Given this list of marker genes HBB, SEMA4D, ZNF148, FRA10AC1 (NCBI Gene Id 57208), DNAAF5, AFF4, VEGFC, ABL1, FANCF, FANCD2, HOXA1, SH3PXD2B, FOXC2, EPHB4, MMP14, INTU, DOCK6, KYNU, DNAJC30, C1R, BMPR1A (NCBI Gene Id 8035), PRDM13, UBAC2, SC5D (NCBI Gene Id 6309), BRAF, CDC42BPB (CDC42 binding protein kinase beta), ERCC6, B3GLCT, WLS, KCNJ8, MED13L, SUCLG1, AGPAT2, TPM2, PPARG, DNMT3A, UBE4B, PKD1L1, SALL4, LPL, EIF4A2, TBL2, CIROP, RNASEH2B, ADK, NOD2, POLR1D, MAPKAPK5 (MAPK activated protein kinase 5), RPL8, HCCS, NEK10, SMPD1, AKT1, BSCL2, SALL1 (NCBI Gene Id 6299), GLI2, PRPF3, SKI, RAD51C, IL10, PPP1R17, MMP2, LTBP1, UBE2T, SMARCE1, LDLR, HRAS, THSD1, SMAD4, NAA20, RPS7, SLC34A2, PIK3CA, NAA60, RAC1, CWC27, DACT1, MKKS, MAX, LMBRD1, FANCL, NOTCH3, CASZ1, COG4, ALG8, NAA10, ABCC6, SLC29A3, DAW1, RRAS, FOXP2, YY1, APOB, ADAMTS17, EGFR, ASCC1, CRB2, FGFR2, RAB34, EXT2, PDCD10, C12orf57, CRELD1, IL12A-AS1, TBX1, RNU4-2, GALNT3, GABRD (NCBI Gene Id 2563), ARID2, HNRNPK, RRAS2 (RAS related 2), PRKACB, ADAMTS19, MPL, CYP1B1, GNA11 (G protein subunit alpha 11), MCTP2, DNAAF4, CR2, XYLT1, HEXA, TAOK1, MED11, CCDC47, RIT1, DHCR7, IL12RB1, APOE, CYP27A1, CRTAP, RBM8A, KCNQ2, ARFGEF2, DPYSL5, KCNN3, SCN2A, SMARCD1, SRCAP, ENG, ECE1, MYPN, CXCR2, P4HA2, SON, IL23R, FUT8, CLXN, ERMARD, RPL35A, SMG8, MYOCD, ADAMTS10, ATP6V1B2, HSPG2, ODAD4, TBX20, TEK, AXIN1 (NCBI Gene Id 8312), BAZ1B, MT-ND4L, SYK, DCDC2, POLR1A, PRDM6, METTL27, TTC12, TMEM270 (NCBI Gene Id 135886), PORCN (NCBI Gene Id 65017), SIX3, MASP1 (NCBI Gene Id 5648), CEP295, EIF4H, UFD1, RASA1, NF1, PLAGL1, FIBP, SF3B2, NODAL, MMP23B, CFC1, PPP2R1A, ZIC3, APP, FAT4, COL1A1, GLB1, F12, UFC1, MYCN, APOA2, TBX5, FADD, CHUK, COMT, RAI1, DOCK8, CCNQ, GLYCTK, DNAI1, NFIX, CSF2RB, SOX4, SOS1, EIF2AK3, LIPA, DIS3L2, SNRPN, DNAJB13, EPHX2, TCF4, LAMB2, PTDSS1, NFIA, RPL11 (ribosomal protein L11), MT-CYB, PRKCD, IL12B, SLC37A4, ALX3 (ALX homeobox 3), CFAP300, PGM1, KCNAB2 (potassium voltage-gated channel subfamily A regulatory beta subunit 2), BPTF, UQCRFS1, DYNC2LI1, NADSYN1, ERCC4, ZIC2, NFKBIL1, RPL18, CD96, TBX4, DNAAF1, TGFBR3, MSX2, FGFR1, LZTR1, SPECC1L, PIK3CD, TMEM94, CFAP298, SLC20A2, DARS1, PSMD12, PACS1, POU3F4, NPC1, KRIT1, KDM5A, PDGFRB (platelet derived growth factor receptor beta), DHCR24, GLI3 (NCBI Gene Id 2737), COQ4, SIK3, MS4A1, RNF213, FOXC1, ERF, LIPC, MAD2L2, DNAAF2, RPS20, TRAF7, ODAD3, UBR7, TNFSF12, MRAS, FOCAD, CTSA, FANCC, RPL5, PIK3R2, NIPBL, PEX1, LEMD2, SEC63, KLRC4, NME8, GEMIN4 (gem nuclear organelle associated protein 4), SLC12A3, PALB2, SMARCA2, FANCA, ZEB2, CLCNKB, GP1BB, SH2D1A, CHD4, HTRA2, COL5A1, NDP, TREX1, GLMN, ROBO1, LRP6, CITED2, NEK9, ARVCF, LFNG, LMX1B, ADAT3, KMT2A, DISP1, IGBP1, CASP10, MLX, PLOD3, SMG9, MAP3K7, MEFV, SERPIND1, VPS37D, NDUFB11, LDLRAP1, LCAT, JAG1, PKD2, GATA4, EED, SCAF4, ZNF687, SUFU (NCBI Gene Id 51684), HLA-DRB1 (major histocompatibility complex, class II, DR beta 1), CPLANE1, LRRC56, HIBCH, TRRAP, SMARCA4, SOX10, WBP4, MT-ND5, BRCA2, LRP5, RPS29, TRIP11, RIN2, MT-CO3 (mitochondrially encoded cytochrome c oxidase III), RFC2, SOS2, BUB1, FANCB (NCBI Gene Id 2187), G6PC3, NEDD4L, ZMYM3, CCDC22, TONSL, DDX6, RSPH1, DNAI2, KAT6A, IFNGR1, HACD1, PPP1R15B, IDS, PCGF2, PKP2 (NCBI Gene Id 93271), NEK8, GPIHBP1, RASA2, CXCR4, IFT56 (intraflagellar transport 56), MT-ND6, WRN, RPGRIP1, SAMHD1, RSPH9, SMC5, FOXF1, AGGF1, TULP1, PRKG1, CBL, NXN, WDR35, CFAP53, PIK3CG, LTBP4, CCNO, POLA1, BUB3, SLC2A10, KDM6A, RPS24, PDPN, TBK1, FMR1, HYMAI, PIGL, ASAH1, STX5, TAF4, GAS1, DRC1, THPO, SPRED2, LYN, CDH2, SCN9A, AGO2, KDR, TWIST1, CSGALNACT1, HDAC4, QRICH1, CFAP74, COX7B, WASHC5, HEY2, GPR35, TMCO1, RPL15, ALDH1A2, GDF2, NCAPG2, SIX6, FBXO11, EMILIN1, ARID1A, GUCY1A1, NPPA, NFKB1, EBF3, TNNT2, SMARCB1, NOTCH1, SHH, THBS2, HYDIN, ODAD1, RPL26, SKIC2 (SKI2 subunit of superkiller complex), HLA-B, ATP2B1, RPS19, DDX59, FANCI, PSAP, MNX1, B3GAT3, IDH1, GBA1, IFT43, GJA8, PGM3, ITPR1, BRD4, OTUD5, JMJD1C, RPL31 (ribosomal protein L31), CREBBP, HCK, GUSB (glucuronidase beta), BANF1, DMPK, MT-ATP6, NLRP3, TRAIP, ATP6V1A, TGFBR2, ANK1, FANCE, COL18A1, NKX2-5, NIPA2, FAS, PDE11A, CELA2A, SPTBN1, PCSK9, CTCF, TMEM260, WNT4, STK36, APOA5, DGCR8, STAT3, GAA, MYRF, WAS, DNAL1, SPEF2, POLR1C, OFD1, GTF2IRD2, RPGR, FBXL4, GM2A, ZFPM2, MEIS2, SUPT16H, SLC39A13, WIPF1, CACNA1C, GAS2L2, MEGF8, LIFR, PKD1, SMAD2, EOGT (EGF domain specific O-linked N-acetylglucosamine transferase), HLA-DPA1 (major histocompatibility complex, class II, DP alpha 1), FASLG, VPS33A, FUCA1, CADM3, EZH2, DYRK1A, CAVIN1, RNASEH2A, RPS10, TNFRSF13B, CEP19, RTL1, GNPAT, MED25, JAK2, RSPRY1, GPC3, ANKS6, HEATR3, BICC1, CTLA4, BRCA1, AGXT, LIMK1, KCNT1, DDX11, BCOR, ODAD2, PTPN22, PRKCSH, CDON, PAH, GATA5, PCNT, SLC22A4, SFTPB, RPS28, EHMT1, AEBP1, PTCH1, RBP4, ACTB, KAT8, ABCD4, ICOS, IL6, ZBTB7A, CCR1, DNAH11, RFWD3, FGFR3, NKAP, COL3A1, SHANK3, DYRK1B, ARX, CDK8, PROS1, STAT1, LOX, DNAJB11, HIRA, PHGDH (phosphoglycerate dehydrogenase), RREB1, SMOC1, MGAT2, TLL1, PLOD1, TALDO1, PDGFB, GPC6 (NCBI Gene Id 10082), YME1L1, BUB1B, MT-ND4, RAD51, SMARCAL1, OTULIN, BRCC3, TRIP4, MEF2A, SSR4, DPM1, UMPS, FARSB, PLXND1, IGFBP7, LARS2, TELO2, SLX4, PNP, UNC45B, TNXB, ACTA2 (actin alpha 2, smooth muscle), CHRM3, TNFSF11, HYOU1, MED12, TBC1D24, CFI, ALG5, RET, RNU4ATAC, GGCX, CYP7A1, MCIDAS, DNASE1L3, AASS, BCR, DGCR6, POLR1B, DVL3, IL12A, PAK2, PPFIBP1, OCLN, GALC, TPM3, THSD4, UBE2A, ALX4, RERE, BRF1, TBCK, USP18, ABCC9, NPR3, MAF, TAB2, PIGO, PSTPIP1, BGN, PTPN6, RPS27, DTNA, NEK1, MID1, PTEN, TRPV6, FBN2, NFKB2, PTPN11, NPC2, CFAP221, LTBP2, TBX2, KIF5A, CCM2, NPHP3, FOS, CDC42, HLA-DPB1, DNAH5, PROC, COA6, APC2, MYH3, ARL6IP6, KDM3B, TSC1, IFNG, TSC2, BRIP1, PRKCZ, SEC24C, TP63, ADAMTSL1, GJA1, FBLN5, C1QB, WAC, RPL35, APOA1, RPS26, CEP120, NIPA1, B3GALT6, FLT4, SKIC3, ARID1B, DNAH9, SOX2, NDE1, VPS35L, ZNF699, CSF2RA, FLNA, PRKAR1A, CCDC40, LSM11, TRIO, RPL9, IFIH1, MAP1B, ATP7A, ZMYM2, ALDH18A1, HTRA1, STXBP1, PPP1CB, XYLT2, RAF1, GHR, DDX3X, KNSTRN, NAE1, ENPP1, RBPJ, MKS1, NSMCE2, GMPPB, KMT2B, COL5A2, DPH5, FIG4, ALG3, CD81, STX1A, BMPR2, CLCN7, CHD7, TGFB3 (NCBI Gene Id 7043), LUZP1, ACP5, BICRA, NSD1, SMAD3, BCL11B, CAV1, ALMS1, XRCC2, KANSL1, WDR19, EFEMP2, PLCB1, PIGN, IRF2BP2, DPF2, PIGT, ADAMTS3, RPS17, TUBG1, RSPH3, KCNE5, FBN1, PLCH1, EP300, DLK1, TFAP2B, TSFM, ANAPC7, EIF2AK4, ELN, PIGA, MYOC (NCBI Gene Id 4653), CHST3, PLD1 (NCBI Gene Id 5337), SRY, SEMA3E, TMEM127, PYCR1, ZFX, AMER1, ESS2, C2CD3, FKBP6, RPS15A, ACVR2B, YY1AP1, FGF8, ARHGAP31, CLIP2, STAT4, PEX12, SELENOI, RAP1B, DLL3, CNTN1, SMC3 (NCBI Gene Id 9126), GANAB, ROBO4 (roundabout guidance receptor 4), ADA2, NEU1 (neuraminidase 1), RAD21, ZSWIM6, GJA5, MMP21, VHL, MT-ND1, NT5E, PUF60, TNFRSF13C, FTO, HEXB, CD19, ZNF462, MYH7, DNAAF6, DOHH, GDF1, ANGPT2, NOTCH2, IPO8, ESR1, SCN1A, CTU2, ABCA1, ALG12, HES7, MFAP5, RSPH4A, KAT6B, MAT2A, STAG2, SPEN, THOC6, MT-ND2, RNU7-1, TGFB2, PAM16, TSR2, FLNB, GJC2, FKBP14, FOXH1, RPL27, FOXE3 (forkhead box E3), UBR1, ESAM, SMC1A, ACSL4, TGIF1, PRIM1, SCN11A, ALG9, SNX14, POGZ, MESP2, ESCO2, TGDS, PEX19, COL1A2, PIEZO1, CD244, STRA6, GPC4 (NCBI Gene Id 2239), TNFRSF1A, FKTN, CCBE1, HPGD, ZMIZ1, NME5, RBM10, IFT140, ATP6V0A2, CIITA, WDR37, ALB, ERAP1, PRDM16, FGF10, WDPCP, SMAD6, TLR4, ADH5, MVK, SDHD, KCNH1, MRPS16, ANO1, FZD4, FANCG, ERCC5, SAMD9, SNX10, GATA6, FOXJ1, ABCG5, ERCC8, RPL10, ROR2, TCIRG1, GTF2IRD1, TMEM67, POLR3F, SLC25A24, ACVRL1, TMTC3, PNPLA2, BMP2, MYLK, CALM3, DLL1, DNAH1, PRTN3, PIK3R1, CRIPTO, MYD88, GNAQ, FANCM, AMMECR1, TRIP13, WT1, PTH1R, NRAS, EFEMP1, CEP57, ATN1, BUD23 (NCBI Gene Id 84118), SLC35A2, XIAP, IGF2, COG6, NCF1, RAB23, EXT1, DLL4, GTF2I, ASXL2, ERCC3, ABCG8, OSGEP, ANTXR1, CCDC39 (coiled-coil domain 39 molecular ruler complex subunit), ADAR, UBE3B, DEPDC5 (DEP domain containing 5, GATOR1 subcomplex subunit), USP9X, MGP, C1S (complement C1s), MAPK1, ANGPTL6, COL4A1, SCN10A, HGD, GATA1, CRKL, ZMPSTE24, RNASEH2C, LMNA, C4A, SPAG1, CARS1, ARF1, DNAAF3, STIL, PLCB3, MST1, BAP1, MYH11, SOX11, NKX2-6, RIPPLY2, TCOF1, BEST1, UBA1, CHRNG, PBX1, SLC25A22, VAC14, TKT, NONO, CUX1, SNRPB, ERCC2, POLR3A, CAT, SLC12A5, MAP2K1, IFT27, GNB2, LRPPRC, ARSL, WDR26, RSPO2, PQBP1, KMT2D, MLXIPL, TGFBR1, FLI1, KRAS, ALX1, ATP6V1E1, ZMYND10 (zinc finger MYND-type containing 10), CBS, SF3B4, DGCR2, ARPC1B, MEG3, SMARCC2, NR2F2, DNAAF11, here is a description of the gene set: Human Gene Set: HP_ABNORMAL_BLOOD_VESSEL_MORPHOLOGY Any structural anomaly of a blood vessel (artery, arteriole, capillary, venule, or vein). Abnormal blood vessel morphology species: Homo sapiens